Given this list of marker genes LGMN, CD55, MX2, DNAJA1, GCH1, CCL5, GTF2B, IRF2, TRIM21, MSX1, PLA2G4A, IFNB1, SLC39A14, RIPK1, IFITM1, HLA-E (NCBI Gene Id 3133), ATF5, H2AC18, NAMPT, SP100, BCL7B, PTGS2, MX1, GBP1, EGR1, IDO1, IFI6, IL6, OAS2, PSMB8, OAS1, NR4A3, WARS1, ISG15, BRCA2 (BRCA2 DNA repair associated), CXCL10, IL11, NR4A1, PML, ALAS1, TNFAIP3, here is a description of the gene set: studied in species Homo sapiens from publication Zhu H, Cong JP, Mamtora G, Gingeras T, Shenk T (PMID 9826724) Human Gene Set: ZHU_CMV_8_HR_UP Up-regulated at 8 h following infection of primary human foreskin fibroblasts with CMV Mechanistic insights to viral replication and pathogenesis generally have come from the analysis of viral gene products, either by studying their biochemical activities and interactions individually or by creating mutant viruses and analyzing their phenotype. Now it is possible to identify and catalog the host cell genes whose mRNA levels change in response to a pathogen. We have used DNA array technology to monitor the level of approximately 6,600 human mRNAs in uninfected as compared with human cytomegalovirus-infected cells. The level of 258 mRNAs changed by a factor of 4 or more before the onset of viral DNA replication. Several of these mRNAs encode gene products that might play key roles in virus-induced pathogenesis, identifying them as intriguing targets for further study.